The following is a description of a gene set: The gene expression profile of peripheral Foxp3+ natural regulatory T cells isolated from Foxp3/EGFP bicistronic mice was compared to that of in vitro-induced regulatory T cells and to CD4+ conventional (Foxp3-) T cells. The role of the regulatory T cell transcription factor Foxp3 in shaping the transcriptosomes of natural and induced regulatory T cells was analyzed using mice expressing a mutant FOXP3-EGFP fusion protein (Foxp3deltaEGFP). We used gene expression microarrays to examine the transcriptional programs of natural and induced regulatory T cells and the function of Foxp3 in organizing the transcriptosomes of the respective cell type Human Gene Set: GSE14415_INDUCED_TREG_VS_FOXP3_KO_INDUCED_TREG_DN Genes down-regulated in induced T reg: wildtype versus non-functional FOXP3. species: Homo sapiens from publication Haribhai D, Lin W, Edwards B, Ziegelbauer J, Salzman NH, Carlson MR, Li SH, Simpson PM, Chatila TA, Williams CB (PMID 19265124), and this is the list of marker genes: PLEKHF1, PRKX, SOAT2, PSMB1, SH2D1A (NCBI Gene Id 4068), PPM1J, PHF11, CHSY1, ZNG1A, F2R, MYO3B, PTPN13, ATP2B1, S100A13, PRDM1, CLYBL, S100A11, MICAL1, PRKCE, EPAS1, ST8SIA4, GLOD4, NFIL3, NDUFA1, TAF9B, ANXA4, CYRIA, LAMC1, MYL4, BET1 (Bet1 golgi vesicular membrane trafficking protein), PCYT1A, GIMAP7, CD28, NPTN, SBDS, ATOH1, PNP, CD44, EDF1, STAT4, IL12RB2, CXCR3 (NCBI Gene Id 2833), GABARAPL2, H2BC4, SLC4A7, ITGA1, NIBAN1, H1-2, DNAJC12, SRGN, ATP6V1G3, GEM, STARD10, IL18RAP, PLAAT3, MRPS24, SERPINB9, CERS4, ABI2, ACOT7, ATP2B4, SMNDC1, RILPL2, RNF216, PTTG1, PLEKHM3, CDC34, ITGAL, TENT5C, PSTK, SAMD3, MFSD6, DSTN, CXCR6, BLVRA, SMPDL3B, ANXA1, ATG5, ECH1 (enoyl-CoA hydratase 1), GINM1 (NCBI Gene Id 116254), PTPRJ, ALCAM, RGS1, ASRGL1, ING2, PPP2R3C, GZMM, HOPX, DMRTA1, SYPL1, PGLYRP1, PMAIP1, GSTP1, SNX10, RAP2A, NDUFAF2, CAB39L, NKG7, NR4A2, SWAP70, MTPN, KCNJ8, TCP1, JDP2, CARHSP1, NELFE, ACSL4, SUMO3, ICOS, FTH1, PSMD14, ARHGAP26, GNPTAB, CD38, SERINC3, AS3MT, ITGAX, HACD2, SNX5, MLKL, PIK3AP1, GPD2, CCL4, GNG10, LRRFIP2, SNX18 (sorting nexin 18), SAMSN1, SMPDL3A, SUCLG1, ZWINT, ATF6, COBLL1, ELOA, TXNDC17, MYADM, SCRN3, CAPG, IL15, MAP3K8, NCALD, TTC39B, TTC39C, CST3, H1-0, TMED10, GALNT3, UIMC1, FAF1, AHNAK, RUNX2, FCGR2B, BEX3, SLC25A24, GSAP, VPS28, CUTA, ATP5F1E, TES, CRYBG1, CHST11, RORA, PRF1, ID2, INSL6, UFC1, ACADL (acyl-CoA dehydrogenase long chain), NDUFS7, DOCK5, DKKL1, SAP30, KLRC2, TMBIM4, SYTL3, CST7 (NCBI Gene Id 8530), ELOB, REEP5, BAG1, ZEB2, CHMP5, RABGAP1L, CYSLTR2